The following is a description of a gene set: Mouse Gene Set: GOCC_ORGANELLE_ENVELOPE_LUMEN studied in species Mus musculus The region between the inner and outer lipid bilayers of an organelle envelope., and this is the list of marker genes: Chchd10, Chchd5, Ak2, Diablo (diablo, IAP-binding mitochondrial protein), App, Bche, Sdhaf3, Micu1 (mitochondrial calcium uptake 1, NCBI Gene Id 216001), Golph3, Timm13, Oma1, Sorl1, Aifm1, Timm8a1, Timm29, Hsd3b2, Prelid2, Pink1, Tubb5, Cdc25c, Thop1, Hsd3b3 (NCBI Gene Id 99715), Fbxl4, Ndufb7, Nme4, Hsd3b9, Fgr, Nradd, Dusp21, Triap1 (NCBI Gene Id 69076), Cox19 (cytochrome c oxidase assembly protein 19), Gatm, Micu2, Prelid1, Akt1, Immt, Timm9, Arl2bp, Trap1, Stoml2, Mix23, Plaat1, Hsd3b1, Rnaset2b, Hsd3b5, Tamalin, Hsd3b4, Suox, Pnpt1, Sod1 (superoxide dismutase 1, soluble), Opa1, Ggnbp1, Cycs, Fkbp10 (FK506 binding protein 10), Nln, Nbr1, Chchd2, Ndufs1, Ciapin1, Chchd7, Ccs, Arl2, Cep89, Prelid3a, Bloc1s1, Ppox, Stmp1, Prelid3b, Chchd2-ps, Them4, Clpb, Dusp18, AU015836, Cpt1b, Uqcc2, Fam3b, Park7, Pank2, Coa7, Igf2r, Alox5, Rexo2, Cacybp, Ndufa8, Coa4, Alpl, Hsd3b6, Cyct, Timm23, Hax1, Ndufs5, Agk, Coa6, Hsd3b8, Htra2, Micu3, Timm10b, Chchd4, Gfer, Cd2ap, Cmc4, Myoc, Ptges, Ccar1, Cox17, Cpox, Timm10, Rnaset2a, Sirt5